Given this list of marker genes DDB1 (damage specific DNA binding protein 1), ITM2B, CLCN4, RCC1, CDC34, RACK1, TRIM58, ATRX, RPL31, PLXNA1, HCP5, PSMB6, RPS5, RBM10, CCND1, FLOT2, DFFA, PDZD2, DNAJB1, OAZ2, NAP1L1, GAS2L1, CSTF2, ZFP36L2 (NCBI Gene Id 96706), SIAH2, CKMT2, PM20D2, CRYAB, NEK3, TCF3, RPL7A, UNG, ALDH18A1, BDH1, ELOF1, CUX1, MAPK1, TP53I3, CTSS, SH2B1, PFN1, GBP1, RPL21, COX6A1, CYP51A1, here is a description of the gene set: Genes down-regulated in response to hydorgen peroxyde in CS-B cells (Cockaine syndrome fibroblast, CS) with defficient ERCC6. Human Gene Set: KYNG_RESPONSE_TO_H2O2_VIA_ERCC6_DN studied in species Homo sapiens from publication Kyng KJ, May A, Brosh RM Jr, Cheng WH, Chen C, Becker KG, Bohr VA (PMID 12606941) Cockayne syndrome (CS) is a human hereditary disease belonging to the group of segmental progerias, and the clinical phenotype is characterized by postnatal growth failure, neurological dysfunction, cachetic dwarfism, photosensitivity, sensorineural hearing loss, and retinal degradation. CS-B cells are defective in transcription-coupled DNA repair, base excision repair, transcription, and chromatin structural organization. Using array analysis, we have examined the expression profile in CS complementation group B (CS-B) fibroblasts after exposure to oxidative stress (H2O2) before and after complete complementation with the CSB gene. The following isogenic cell lines were compared: CS-B cells (CS-B null), CS-B cells complemented with wild-type CSB (CS-B wt), and a stably transformed cell line with a point mutation in the ATPase domain of CSB (CS-B ATPase mutant). In the wt rescued cells, we detected significant induction (two-fold) of genes out of the 6912 analysed. The patterns suggested an induction or upregulation of genes involved in several DNA metabolic processes including DNA repair, transcription, and signal transduction. In both CS-B mutant cell lines, we found a general deficiency in transcription after oxidative stress, suggesting that the CSB protein influenced the regulation of transcription of certain genes. Of the genes, 122 were differentially regulated by more than two-fold. Evidently, the ATPase function of CSB is biologically important as the deficiencies seen in the ATPase mutant cells are very similar to those observed in the CS-B-null cells. Some major defects are in the transcription of genes involved in DNA repair, signal transduction, and ribosomal functions.